The following is a description of a gene set: Any process of the immune system that executes a component of an immune response. An effector immune process takes place after its activation. studied in species Homo sapiens Human Gene Set: GOBP_IMMUNE_EFFECTOR_PROCESS, and this is the list of marker genes: CTSH, HK1 (NCBI Gene Id 59333), RAET1E, CDH17, PHB1, PIK3CB, BTN3A3, STAP1, PAK1, MPO, IGLL1, CD37, RSAD2, GRB2, STX4, RELB, RAB27A (NCBI Gene Id 5873), NCF1, GAB2, COLEC11, DDX21, IRF5, ENPP3, RPS19, IGHV3-23, VAMP3, POMC, EXO1, PTK2B, CD1A (CD1a molecule), SASH3, INPP5D, IRF7, P2RX7, STAT3, HTR2A, TUSC2, NLRP6, IGHV3-53, PCYT1A, PLCG2, IL2, NOS2, PIK3CG, PCYOX1L, SPHK2, RIPK2, TRPM4, PGLYRP2, BRD4, PCK1, DOCK11, IL23A, GATA1, RARA, CD177, PLEC, PDP2, IFNB1, ULBP1, CRACR2A, FCGR2A, NLRP3, C9, IGHV5-51, FES, AZU1, CD86, IGHV3-74, LAMP1, ULBP2, TICAM1, CD84, IFNA17, FER, C5, IGHV3-15, CD40, IGHV3-21, HLA-B, PIK3R6, MRGPRX2, GKN2 (gastrokine 2), FCGR2C, CR1, LGALS9, GPI, FCGR3A, EVPL, MAVS, HPX, PTK2, IGHV1-69D, IFNA5, CD27 (CD27 molecule), CD28, IL2RB, IL4R, RASGRP1, PGLYRP3, NOTCH2, TBK1, CD1D, CD274, FADD, LCP1, BCR, FCER1G, SH2D1B, PHB2, HLA-DRA, PANX1, SOCS3, NECTIN4, CGAS, SLC22A13, IGHV5-10-1, KLRF2, ENTPD7, SLAMF6, MTOR, IL4, RAET1L, MEN1, PDPK1, ZBTB7B, FCN1, IGLL5, BST2, SWAP70, CD5L, IGHV3-43, CD2, DUSP22, KLRK1, STXBP2, TNFRSF14 (NCBI Gene Id 93208), LAT2 (NCBI Gene Id 7462), LILRA2, SOCS5, ERCC1, CD80, ADAM10, CCL19, VAV1, MYO1G, ZP3, CADM1, TFRC, IGHA2, C1QC, IFNG, LRP1, ZNF683, ARL8B, IL9R (NCBI Gene Id 3581), NCR1, SBNO2, TIGIT, SERPINB9, COLEC10, LGALS8, IL10, PTPN6, SLA2, LY9, KLRB1, CD160, GPRC5B, LAG3, PRKCE, SNAP23, KMT5C, ATAD5, APPL2, IGHV4-59, MFNG, RNF8, ITM2A, ACE, TRIL, STAT5A, HPRT1, NECTIN2, USP17L2, PLPP4, SUSD4, CD81, UFL1, FCAR, ULBP3, MYB, CRP, MASP1, CALHM6, PRDX2, FCER1A, SRC, IGHV4-4, HMCES, KLRC1, SPN, NR4A3 (NCBI Gene Id 8013), RAC2, IL9, CYRIB, TP53BP1, KLHL22, CLEC4G, IL13RA2, YWHAG, CD7, RIF1, VAV3, SUPT6H, GALNT2, LYN, SUCNR1, RIPK3, C8A, C1QB, MYD88, IFNA7, CRK, C8G, JAG1, FCGR3B, SCN11A, IL17A, MLH1, IGHG1, ARG1, HSPD1, IGLC2, CLEC4D, CFD, PVR, ARRB2, PRKCZ, CD22, CCL3, AICDA, MILR1, BCL3, GBF1, CD69, TMBIM6, SCART1, CTSG, PLD2, PAXIP1, VSIG4, LIPA, PLEKHM2, TLR7, TNFRSF4, C7, ZC3H12A (NCBI Gene Id 80149), WAS, GNL1, SNX4, SERPING1, CD36, ADAM17 (ADAM metallopeptidase domain 17), LEP, IL13RA1, IGHV1-69-2 (immunoglobulin heavy variable 1-69-2), ASCL2, IGLC3, TWIST1, C4A, IL27, KLRC4, CEBPB, FCN3, TCIRG1, OPA1, IGHV2-70, RNF19B, LIMK1, CD300A, NKX2-3, IFNA16, PLXNA1, IL23R, HLA-DMB, DOCK10, CFHR5, TNFSF18, CAMK4, SEMA4A, ARID5A, IL13, PIK3R1, ICAM1, RORA, CD96 (NCBI Gene Id 337949), FGR, IGHV3-13, CPLX2, LEF1, IL18R1, STAT5B, FCGR1A, NDFIP1, KIR2DL4 (NCBI Gene Id 653757), PLCL2, SLAMF1, CLEC4E, AHR, CD226, IRF8 (interferon regulatory factor 8), IGHV4-39, PTPRC, AP1G1, LFNG, NKG7 (natural killer cell granule protein 7), KLK5, MAPK3, GZMM, VAV2, IL18RAP, PYCARD, TNFSF4, ITGB2, IGHV7-81, NMI, TRAF6, JAK1, PRAM1, PRF1, IL4I1, IGHD, SEMA7A, CUEDC2, IGHV3-35, INS, MAPKAPK2, TAOK3, EIF2AK4, IGHV1-3, IRF4, ANKRD17, CHGA, S100A13, CBL, POU2AF1, TGFB3, KMT2E, IL2RG, GPR65, LBP, FOXF1, VAMP7, KDM5D, IGHV3-33, LACC1, SHLD3, IGLC7, MALT1, TREX1, FOXJ1, IGHV3-30, UNG, DENND1B, JUNB, FUT7, MASP2, SLC18A2, IL20RB, IGHV4-31, MIR302A, PGC, CLC, NOD1, CD74, ICOSLG, MICA, BTN3A2, PIK3CD, APBB1IP, LTA, FOXP1, DOCK2, CFP (complement factor properdin), IL18, EPHB2, DHX58, NLRX1, JAGN1, FCER2, C1S, APOA1, TYROBP, UBE2J1, PKP3, CLEC7A, ZPBP2, SNX6, LAPTM5 (lysosomal protein transmembrane 5), RORC, FCMR, STAT6, ST3GAL1, SLC7A5 (NCBI Gene Id 8140), KLRC3, SECTM1, CLEC2A, IGHV7-4-1, DNASE1, IFNW1, WDR1 (WD repeat domain 1), IFNA14, FCN2, CRTAM, C4B, IGHV4-34 (immunoglobulin heavy variable 4-34), CFHR3, IGHG2, VAMP8, SHB, IL7R, DLL1, SLAMF7, KLRC4-KLRK1, CFH, SHLD1, NCR3, CSF2RB, IL6ST, CFI, NDST2, KIF5B, XCL1, DBH, IL27RA, TREM2, NFKBID, APLF, IFI35 (interferon induced protein 35), SMAD7, IGHV1-58, GATA2, MIR520E, KRT1, BTK (NCBI Gene Id 695), ELANE, PARP3, WNT5A, GRN, SCIMP, TLR3, STAT4, CR2, CD8A, EP300, LOXL3, FFAR3, C1R, TLR4, IFNK, ICOS, TMEM98, MR1, S100A9, SELENOK, STX7, FBXO38, CFHR4, IFNA21, SHLD2, CORO1A, HAVCR2, MBL2, IFNA8, FYN, MIF, HLA-F, IGHV4-28, PTX3, EBAG9, C1QA, TLR8, SCNN1B, STXBP3, HCK, NBN, ABL1 (NCBI Gene Id 25), FOXP3, APPL1, PRDX1, SERPINB4, IGLC1, IL17F, DDRGK1, C1QBP, CD40LG, RAB44, MAD2L2, IFNA6, DDX1, RC3H2, TBX21, IGHV2-5, B2M, ADA, IGHV3-73, CFHR1, SEMA6D, KMT2A (NCBI Gene Id 79951), FCGR1BP, ATG5, HFE, XBP1, C4BPB, IFNA4 (interferon alpha 4), IGLC6, GPR183, CD1E, RABGEF1, TGFB2, TP53, LGALS3, NOD2, UNC93B1, JAK3, DNASE1L3, DEFB131A, CD19, RAET1G, IL5, DUSP10, GAPT, CCR2, CX3CR1, IGHV1-45, TNFRSF1B, CARD9, C1RL, GZMB, IGHV8-51-1, IGHG4, PRKAA1, KLRC2, ZBTB1, VAMP2, IGHV3-72, IL33, IFNA2, FCGR2B, FGL2, LYST, PDCD1, LIG4, CFHR2, IGHV3-16, GFUS, SANBR, IGHV1-69, NFKBIZ, F2, ATG9A, CD180, FCRL3, TRAF2, SFTPA1, PTGDS, HLA-H, HMGB1, PLA2G6, GPR15LG, MYO18A, GRP, CFB, IGHV6-1 (NCBI Gene Id 28385), C6, IGHV3-20, STXBP1, TAP2, IFNA10, C2, AZGP1, SPI1, ADGRE2, PTGDR, IGHV2-26, RC3H1, MDK, TSC1, IGHV3-64, CD1B, IL12RB1, IL6, IRAK4, CLU, SLC15A4, IGHV3-48, SYK, BRD2, CTSC, PSEN1, HLA-C, IGHV1-18, UNC13D, ACP5, CD70, HLA-A, PTGER4, CEBPG, INAVA, RASGRP4, IGHV3-66, RTN4, KMT5B, DYSF, MAP3K7, A2M, NSD2, FERRY3, BCL6, PLA2G1B, EXOSC3, EXOSC6, IFNE, CD46, LILRB1, KLK3, KIT, CCR6, RBP4, IGHV1-24, IL12B, IL6R, FZD5, AXL, EOMES, IL12A, PKN1 (NCBI Gene Id 5585), ITGAL, IGHV4-61, TUBB, F2RL1, CLNK (NCBI Gene Id 116449), IFNL1, EMP2, HLX, DAO, TREM1, DNAJB9, ZFPM1, PMS2, IFNA1, BCL10, TGFB1, PLA2G3, GATA3, ADORA2B, LAT, MSH6 (NCBI Gene Id 2956), NCKAP1L, ANXA3, CXCL6, IGHV3-7, LITAF, IGHV3-49 (NCBI Gene Id 652113), MSH2, CD55, ITFG2, MIR21, IRAK3, ANGPT1, C17orf99, TRIM6, YES1, IL21, IL1B, TNFSF13, KIR3DL1, SLC11A1, CYBC1 (NCBI Gene Id 79415), ATP7A, FCRLB, HCST, PRKCD, IGHG3, USP5, TRAF3IP2, PGLYRP1, IGHV3-64D, SIRT1, APP, EPX, CEACAM1, HLA-DRB1, KLRD1, KARS1 (lysyl-tRNA synthetase 1), CR1L, PHF14, MIR520B, TNF, SLAMF8, C8B, ANXA1, FFAR2, IL1R1, ITGAM, APOA2, RFTN1, HLA-DRB3, IGHV2-70D, CLEC12B, IGHV3-38, KLK7, IGHV3-11, HLA-E, BATF, DDX60, HLA-G, MZB1, SH2D1A, LILRB4, CLCF1, AIRE, PLA2G5, LGALS1, RIGI, RNF168, TUBB4B, IGHE, CD244, RAG2, C4BPA, IGKC, PRG2, CD59, PPP3CB, DHX36, AGER, SPINK5, SPON2, C3, TCIM (transcriptional and immune response regulator), TLR9, IGHA1, CD1C